Given this list of marker genes Sqle, Plpp6, Srebf2, Arv1, Idi1, Dhcr24, Lbr, Nsdhl, Cyp51, Dhcr7, Idi2, Hmgcs1, Tm7sf2, Fdft1, here is a description of the gene set: This event has been computationally inferred from an event that has been demonstrated in another species.<p>The inference is based on the homology mapping from PANTHER. Briefly, reactions for which all involved PhysicalEntities (in input, output and catalyst) have a mapped orthologue/paralogue (for complexes at least 75% of components must have a mapping) are inferred to the other species. electronically inferred by orthology from the curated human pathway Reactome Pathway: Cholesterol biosynthesis part of: Metabolism of steroids species: Mus musculus